Given this list of marker genes RPL17P14, ENSG00000212391, CRIPTOP2, SCG2, RRAS2P2, COL4A4, AP1S3, RNU6-619P, EPHA4, RNU6-624P, RNA5SP121, RNU7-9P, SLC19A3, FARSB, DNER, HIGD1AP4, AGFG1, FAM124B, RN7SKP283, TRIP12, CCL20, ENSG00000299331, TMEM256P2, ACSL3-AS1 (NCBI Gene Id 105373904), NYAP2, SCYGR10, PAX3, DOCK10, RNU6-613P, MFF, GAPDHP49, FBXO36, CCDC140, HSPA9P1, ANKRD49P1, RNU6-1027P, MIR5702, SNRPGP8, IRS1, RPL23P5, ATG12P2, MIR4439, RNF228, SCYGR7, FBXO36-IT1 (FBXO36 intronic transcript 1), RNY4P19, RPL7L1P10, CUL3 (NCBI Gene Id 8452), SGPP2, RPL31P17, RN7SL807P, MRPL44, LINC01807, LLPHP3, WDFY1, USP21P1, SCYGR3 (NCBI Gene Id 112441429), SCYGR5, SERPINE2, SCYGR2, MOGAT1, MLXP1, SLC19A4P (NCBI Gene Id 56918), NANOGP2, SCYGR8, MIR5703, RHBDD1, SPHKAP, SCYGR9, SNF8P1 (SNF8 pseudogene 1), PID1, ENSG00000303347, DAW1, SCYGR1, SCYGR6, MFF-DT, ENSG00000287791, SLC16A14, RPL23AP28, TM4SF20, COL4A3, SCYGR4, CT75, CCDC195, KCNE4, RNU6-964P, ACSL3, here is a description of the gene set: Human Gene Set: chr2q36 studied in species Homo sapiens